The following is a description of a gene set: Neighborhood of PHB studied in species Homo sapiens Human Gene Set: MORF_PHB Neighborhood of PHB prohibitin in the MORF expression compendium, and this is the list of marker genes: HMG20B, HNRNPL, ADAM15, ARIH2, OTUB1, BAHD1, PAX8, NUP62, AATF, DDB1, TERF2IP, SLC25A11, PSMD3, PCBP3, GNL2, TCOF1, SRRT, TP53BP1, RPA2, ERAL1, NELFB, SLC12A4, IDH3A, PARN, MFN2, SFSWAP (splicing factor SWAP), WDR62, DRG2, ESYT1, FANCG, KAT2A, SPRN, WDR18 (WD repeat domain 18), LSM12, PWP1, PRKCSH (NCBI Gene Id 5589), MTX1, RTCB, TMEM94, COPS6, CPSF4, ELK1, EBP, PPP1R11, CNP, RPRD2, MGAT1, SCARB1, PFDN1, FDXR, DRG1, PKMYT1, ILF2, CNPPD1, CS, BRD3, TFAP4, STK19, PRKAG1, NFYB, MEA1, GRK6, PCGF1, POLR2A, NUP188, DDX18, TIMM17A, TPR, GFUS, DNAJC8, TOMM34, DYRK2, DDX11, ZPR1, PLIN3, CCT4, XPO6, BMS1, AGPAT1, TUBGCP2, RBBP8, CDC25C (cell division cycle 25C), MPST, SDR39U1 (short chain dehydrogenase/reductase family 39U member 1), PHB1, CAD, NAP1L4, IGSF9B, PABPN1, ENTREP3, IFRD2, IKBKG, ZNF271P, NUDT3, GPAA1, PRPF8, BPHL, ZBED1, NFRKB, ALDH4A1, SH2B1, PCGF2, PSD4, MLEC, CSTF3, USP5, ILVBL, RABGGTA, NDST1, DAXX, EML3, AFG3L2, CHD3, CIB1, CSNK1D, B4GALT3, MRPL28, EIF6, PSMD2 (proteasome 26S subunit ubiquitin receptor, non-ATPase 2), METAP1, TEX261, MCRS1, VARS1, DNAJC7 (NCBI Gene Id 7266), PSMB6